Given this list of marker genes Wnt5a, Crb3, Sh3bp1, Patj, Syne4, Carmil2, Gbf1, Tcf15, Map1b, Prkci, Ophn1 (NCBI Gene Id 94190), Spag6l, Fat1, Camsap3, Nherf1, Ift20, Scrib, Cdc42, Myo9a, Foxf1, Msn, Ttc8, Foxj1, Lama1, Fscn1, Rhoa (NCBI Gene Id 51787), Ptk7, here is a description of the gene set: Mouse Gene Set: GOBP_ESTABLISHMENT_OR_MAINTENANCE_OF_MONOPOLAR_CELL_POLARITY studied in species Mus musculus Any cellular process that results in the specification, formation or maintenance of monopolar intracellular organization or cell growth patterns. Monopolar cell organization is directional organization along an axis.